Given this list of marker genes Bcl9l, Tle4, Ldb1, Tle1, Ctnnb1, Bcl9, Tcf7l2, Pygo2, Tcf7, Lef1, Tcf7l1, Tcf4, Tle3, here is a description of the gene set: studied in species Mus musculus A protein complex that contains beta-catenin and a member of the T-cell factor (TCF)/lymphoid enhancer binding factor (LEF) family of transcription factors. Mouse Gene Set: GOCC_BETA_CATENIN_TCF_COMPLEX